Given this list of marker genes Strn4, Lef1, Strn3, Axin1, Cnot1, Ctnnbip1, Tcf7l2, Chd8, Strn, here is a description of the gene set: Mouse Gene Set: GOMF_ARMADILLO_REPEAT_DOMAIN_BINDING studied in species Mus musculus Binding to an armadillo repeat domain, an approximately 40 amino acid long tandemly repeated sequence motif first identified in the Drosophila segment polarity protein armadillo. Arm-repeat proteins are involved in various processes, including intracellular signaling and cytoskeletal regulation.